Given this list of marker genes ANP32E, PAX6, NNMT (nicotinamide N-methyltransferase), ISG20, KRT16, CHI3L1, CYP1B1, CD1E, TCF7L2, ELF5, EMCN, TNFRSF11B, PDPN, IGLV3-10, DPT, MPZL2, CDKN1C, CLIC4, MT1M, PTGFR, APP, AMD1, DEFB1, SNCAIP (synuclein alpha interacting protein), IGKV1OR1-1, DTX4, SEL1L3 (SEL1L family member 3), FABP7, KRT6A, DSC3, IGF2, FBLN1, MUC16, YBX3, GZMB, ICOS, CYP39A1, FOLR1, MARCO, FAT1, RIPK4, CAV2, GABRP, NKG7, FAS, CD24P4, TNXA (NCBI Gene Id 7146), RND3, RAC2, TRBC1, C1S, CD1C, PRKX, KYNU, ZIC1, TRDC, TRAF3IP3, RGS2, IGKV1OR2-108, PALS2, DCN, PLPP3, IGLV3-19, CCL2, IGKV1D-37, GAD2, CD48, TCEAL2, GSTA1, RGCC, GEM, FRZB, WNT6, BIRC3, PECAM1, IGHV3-21, CSF2RA, IL7R, HOXA9, FOXC1, ITM2C, TMEM45A, CHST7, PFKP, SELE, IGLV3-25, NMU, ENPP2, KLK6, TBX19, LTBP1, RCAN1, KLF5, COTL1, EGFL6, ELN, TNNI2, CCL21, FBLN2, TRBC2, SRGN, SRPX, UBE2E3, MAP1B, CXCL2, SYNGR1 (synaptogyrin 1), P2RY14, MYLK, MICALL1, TIE1, PGRMC1, FNDC3B, GPR161, NUDT11, TRIM29, KRT15, LYVE1, IGHV3-23, CD3D, IDO1, MAPRE2, SLC2A3, PVRIG, FAM107A, NPR3, MYCN, DSG3, PTN, CLDN1, KRT5, GZMA, HACD1, IGF2BP3, IGKV4-1, CRYAB, PTPN22 (NCBI Gene Id 5779), TDO2, GIMAP5, MIA, CTSW, PDE9A, FMO2, CDKN2A, WARS1, HBB, RAB23, ID4 (NCBI Gene Id 3400), ADM (adrenomedullin), S100A8, HLA-DRB4, TET3, ALDH1A1, MEOX2, LAMB3, CYP26B1, PLSCR3, IL2RG, SOX10, TCL1A, CHI3L2, YBX1, CHST3, CCN1, PTP4A3, ADAMTS1, IGLV2-14, CCL18, IGHV3-33, SFN, LYZ, PTK7, CCL13, SIT1, NPTX2, TNFRSF4, PADI2, IFI16, VNN1, FOXO3, CCL19, TMSB15A, CCL20, C3, CR2, ITM2A, LCN2, CSRP2, LPL (NCBI Gene Id 4023), GABRE, SLC25A37, BIN1 (bridging integrator 1), LTB (lymphotoxin beta), WWTR1, ID1, FSCN1, IGF1, DSC2, GBP1, GSDMB, ACAP1, IL27RA, PTPRC, CLDN8, TRAT1, CLEC10A, ITGA6, DKK1, PAPSS2, LMO4, GPR18, CYTL1, PTCH1, NFIB, PI3, KLRC1, ORM2, CYTIP, MMP3, CD52, MID1, PLCH1, KLRB1, PLAC8, PKP1, TAGLN, MALL, DOCK2, KLK7, SERPING1, CD2, PIK3CD (phosphatidylinositol-4,5-bisphosphate 3-kinase catalytic subunit delta), CYBA, ABCC4, KHDRBS3, SV2B, KRT86, NKX2-5, GJB3 (gap junction protein beta 3), MME, PPP1R16B, BAG2, MSN (NCBI Gene Id 4478), CCN2, HSPB2, CFI, KRT7, IGKC, PLA2G4A, CLCN4, SH2D1A, NFKBIL1, NFIL3, CD7, CD247, B3GNT3, KCNN4 (potassium calcium-activated channel subfamily N member 4), MRAS, CRLF1, IGKV1D-13, LTF, SERPINH1, CH25H, SCRG1, SAT1, IGFBP3 (NCBI Gene Id 3486), NDRG1, ANXA3, PLTP, SFRP1, FERMT1, MMP1, PLAAT1, COL4A2, ADGRF5, CX3CL1, TRAC, VNN2, LYN, GALNT12, CD38, ICAM1, GLIPR1 (NCBI Gene Id 11010), ARHGAP25, TNFAIP3, SOSTDC1, SRD5A1, CLEC4A, CHRDL1, AKR1C1, IL32 (interleukin 32), ITGA7, IGHV4-34, DST, CORO1A, KRT6B, SFRP4, MFAP4, INAVA, CD27, FNDC4, ADAMDEC1, CRABP1, MT1X, ZNF532, MRC1, ANK2, KLF6, ST8SIA1, ADGRG6, PELI1, FZD7, SOX11, MMP7, TNFRSF21, SLC43A3, IL6, EDN2 (endothelin 2), PERP, CHODL, S100A9, IGKV1D-39 (immunoglobulin kappa variable 1D-39), CSGALNACT1, IGHD, IGF2BP2, TTYH1, SLC6A15, PLIN1, MYH11, SLC6A14, PAMR1, RARRES1, MET, PTGIS, NUP93 (NCBI Gene Id 9688), ANXA8, PROM1, CCL5, POU2AF1, CAPN6, EGFR, LILRA4, GUCY1A1, SPIB, LEPR, AQP1, IL1R2 (NCBI Gene Id 7850), NLRP1 (NCBI Gene Id 82286), MT1F, KRT17, TNFRSF17, STXBP6, GPM6B, NES, CLIC2, IGHM, STEAP1B (NCBI Gene Id 402466), TSPAN8, FCER1A, SERPINE2, MMP14, CD19, CALD1, IGKV2D-28, GALNT3, MICAL3, APOD, TMEM100, KRT23, MZB1, PROS1, S100A2, DLX5, LBP, HLA-DQB1, ADGRG2, BCL11A, GAL, CXCL11, FYN, DMD, ADD2, CALB2, LY9, WIF1, APBA2, CCN3, PGBD5, JRKL (JRK like), WLS, LCK, ANGPTL4, STAP1, BCL2A1, PRKCB, HOXA5, SLPI, CTSC, ZAP70, IGHA1, PHGDH, KLRK1, RIPOR2, CHRM3, ACTG2, CD3G, RYR1, MCM5 (minichromosome maintenance complex component 5), ART3 (ADP-ribosyltransferase 3 (inactive)), MEAK7, IGLL3P, NSG1, TFPI, SLC16A1, TMEM158, SMCO4, CHAC1, GPR19, GZMH, KLK5, HSD17B2, CA9, PTGS2, MFGE8, MPPED2, PRKD3, CAV1, CD37, CLCA2, TM4SF1, PLA2G2A, VGLL1 (NCBI Gene Id 51442), RRAS2, CCR7, FOLH1, BACE2, TCF7L1, SYNM, LBR, COL9A3 (collagen type IX alpha 3 chain), KCNG1, KLK10, IGLC2, GNLY, AKR1B10, HLA-DQA1, PCOLCE2, PML, DZIP1, IGHV1-69, ANXA1, RBMS1 (RNA binding motif single stranded interacting protein 1), RASGRP2, LGALS7 (NCBI Gene Id 3963), RUNX3, BIN2, ADCY2, LY6D, PRRX2, ALDH1A3, FHL1, C7, PSAT1, GRB14, SAA1, ICAM2, CXCL8, FLNA, DLK1, ADD3, CCL14, PTPRCAP, VCAN, HLA-DRA, IL33, TTLL4, PLAGL1, S100A7, EN1, MAP4K1, FABP5, FERMT2, SVEP1, WTAP, GABBR1, NINJ2, NDRG2, HLA-DOB, PPP1R1A, SHOX2, GZMK, LGALS2, CXCL1, PTX3, P2RX5, IRAG2, HBA1, ANGPT1, CXCL9, CXCL12, CXCL10, RRAGD, S100B, UGT8, TRIM2, CYRIA, BBOX1, FBXO17, TNFAIP8, ARL4C, COL14A1, GRAMD2B, PDGFRA, FAM171A1, PDZK1IP1, L1CAM, CDH3, STK10, GSTP1, ADH1B, PTPRZ1, VPREB3, IGHV4-61, KCNK5, DNAJB4 (DnaJ heat shock protein family (Hsp40) member B4), SOD2, GABBR2, RBP4, IGHV3-7, FBLN5 (fibulin 5), EDN1, IGHV3-47, IGKV1D-17, EXTL1, ASS1, IL12RB2, KIT, BCL11B, CALML5, KRT14, PTGER4, VCAM1 (vascular cell adhesion molecule 1), CD79B, CRYBG1, EPB41L2, SELL, GPR171, KRT81, NCF1, ACKR1, IGHG1, ABCA8, ITK, DNM3, CCR2, IGKV3-20, LAMP3, ITGB7, MS4A1, BTN3A2, EFEMP1, CD96, IL21R, LAD1, TAP1, CD69, PRELP, ABCC2, DTNB-AS1, FHOD3, CLIC3, SLC34A2, IMPA2, BANK1, XCL1, JCHAIN, S100A1, ACE2, DEPP1, CD79A, ACADL, HLA-G, LDHB, MFAP2, GPR183, ROPN1, TNC, here is a description of the gene set: Genes down-regulated in the luminal B subtype of breast cancer. Human Gene Set: SMID_BREAST_CANCER_LUMINAL_B_DN from publication Smid M, Wang Y, Zhang Y, Sieuwerts AM, Yu J, Klijn JG, Foekens JA, Martens JW (PMID 18451135) We explored whether the five previously reported molecular subtypes in breast cancer show a preference for organ-specific relapse and searched for molecular pathways involved. The intrinsic gene list describing the subtypes was used to classify 344 primary breast tumors of lymph node-negative patients. Fisher exact tests were used to determine the association between a tumor subtype and a particular site of distant relapse in these patients who only received local treatment. Modulated genes and pathways were identified in the various groups using Significance Analysis of Microarrays and Global Testing. Bone relapse patients were most abundant in the luminal subtypes but were found less than expected in the basal subtype. The reverse was true for lung and brain relapse patients with the remark that absence of lung relapse was luminal A specific. Finally, a pleura relapse, although rare, was found almost exclusively in both luminal subtypes. Many differentially expressed genes were identified, of which several were in common in a subtype and the site to which the subtype preferentially relapsed. WNT signaling was up-regulated in the basal subtype and in brain-specific relapse, and down-modulated in the luminal B subtype and in bone-specific relapse. Focal adhesion was found up-regulated in the luminal A subtype but down-regulated in lung relapse. The five major molecular subtypes in breast cancer are evidently different with regard to their ability to metastasize to distant organ(s), and share biological features and pathways with their preferred distant metastatic site. species: Homo sapiens